The following is a description of a gene set: Human Gene Set: GTATTAT_MIR3693P species: Homo sapiens Genes having at least one occurence of the motif GTATTAT in their 3' untranslated region. The motif represents putative target (that is, seed match) of human mature miRNA hsa-miR-369-3p (v7.1 miRBase)., and this is the list of marker genes: UBE2D3, ZFHX4, HOXB3, AFF2, BCAS1, RSBN1, PCDHA1, PCDHA9, TRPS1, PDE4B, EP300, VSNL1, CD2AP (NCBI Gene Id 25916), PTCH1, PPP2R2C, LIMK1, ZNF395, LARP1, CEBPB, PAX6, NIPBL, BACE1, SPRED1, TNRC6B, FLRT3, AGAP1, PPP1R12A, SMARCA1, DR1, AFAP1L2, PCDHA3, TCF12, MEIS1, SIRT1, MMD, GABRB3, VEZF1, TAF5, ST8SIA2, FBXW11, TRAPPC8, MAL2, FOXN2 (NCBI Gene Id 3344), PCDHA10, ELMOD1, ETV5, ZFR, PCDHA12, NUAK1, CNBP, PIKFYVE, PCDHAC2, LTBP1, ATMIN, PDE7B (phosphodiesterase 7B), PDE4D, RNF13, KIF20A, PCDHA8, NR2F2, TUT4, SPAG7, CHST15, MBNL2, FOXO1, ZDHHC17, UCHL3, RFX4, BMPR2, BAZ2B (NCBI Gene Id 29994), AMFR, ARHGAP6, NCOA3, RNF11, RAI1, LRP1, YTHDF3, RBM26, ZFAND6, PCDHA7, BICD2, CASK, PNRC1, PCDHA13, FOXG1, EYA1, TMEM117, RAB3GAP2, ADAM10, MOB4, VEGFC, KCNJ3, CEP41, UBE2E2, FNBP1L, GLRB, CILK1 (ciliogenesis associated kinase 1), STYX, DNAJC6, ACVR2A, HAO1, PIANP, HSPH1, FNIP1, SLC39A10, SEZ6, ZNF281, NCK2, ARL2BP, TLN1, RELCH, OXR1 (NCBI Gene Id 55074), PCDHA5, PCDHA4 (NCBI Gene Id 56144), ADAMTS6, SULF1, OSBPL11, SUN2, PCDH19, NCBP3, PKIA, NOG, PCDHA11, ADGRL2, DNAJB5, BOLL, CDK19, ARHGAP28, ZDHHC9, ADAMTS19, PCDHA2, CBX4, CASR, AP2A1, SETD2, MBNL1, FYN, PRKCA, FAM135A, PLPPR1, MEX3B, PLPPR4, SP3, EFNB2, GFRA2, MSL2, CLIC4, SRPK2, RNF38, GIT2, YAF2, EPS8L2, DIP2C, RAB10, MGAT4A, ADAMTS3, ZMYND8, ARID4A, ZEB1, RAB11FIP2, QKI, GOPC, RBM33, ARID2, ZFAND5, TLX3 (T cell leukemia homeobox 3), ZNF711, PCDHAC1, CREBRF, DMD, BRD8, SOX4, TLE4, WSB1, KMT2A, ATP8B5P, PAXIP1, ZNF423, NUMBL, WBP4, RBSN, PELI1, SLC6A1, CFL2, HES1, PTPN12, KCTD8, WDR20, KLHL3, NBR1, CDH2, CHD7, ZEB2, NPTX1, SFSWAP (NCBI Gene Id 6433), MED13, MYLK4, ZFPM2, GPR85, LRP1B, NUP93, RPS6KB1, PCDHA6, CCNE2, ST3GAL3, MAP2, CAPZA1, CAPZA2